Given this list of marker genes TMOD2, MET, PIK3R2, CLASP1, LMOD1 (NCBI Gene Id 25802), TMSB4X, ADD3, CCL21 (NCBI Gene Id 6366), SPTBN4, DNM2, CCL26, WASHC2C, BAIAP2L2, CD2AP (NCBI Gene Id 25916), MAP7D3, MECP2, NCK1, MLST8 (MTOR associated protein, LST8 homolog), TPPP, SKA1, CYRIB, NCK2, FER, CSF3, ARFGEF1, HAX1, PPP2CB, SSH3, PREX1, ASB2, SSNA1, MKKS, CDK5R1, TRIM6 (tripartite motif containing 6), NAV3, CAPZB, HDGFL3, CCDC57, CARMIL2, PLEKHG2, MAPRE1, TPPP3, SPTBN5, AKAP9, CAPG, ESAM, TUBB1, UBE2K, TUBGCP5, STMN1, MICALL2, HAUS3, NIN, TUBGCP4, HAUS7, CDC42EP3, DYRK1A, SLAIN2 (NCBI Gene Id 80106), ARPC2, WASF1, PYCARD, MAPRE3, ANKRD53, TUBGCP6, HCLS1, ADD2, RAC1, NCKAP1L, PRKCD, FLII, WASHC3 (WASH complex subunit 3), FGG (fibrinogen gamma chain), PRKN, FAM107A, PSRC1, TUBG2, GSN, RDX, RICTOR, CDH5, HCK, FES, AVIL, KIRREL1, BAIAP2L1, WASHC5, PRKCE, CHMP4A, CHMP2A, C15orf62, CHMP4B, RPS3, ARPC5L, MZT1, CFL1, TMOD4, CAMSAP2, CKAP5, PFN2, PRUNE1, ABL1, TUBA1A, ARL6, VIL1, TWF2, WASF3, KANK1, VTN, MAP1B, UBE2C, SNX9, CLIP1, CORO1A, DIAPH3, AMBRA1, ALOX15, TMOD3, ARHGAP40, TRIOBP, KRT5, KIF21A, ADD1, HAUS8, CAMSAP1, VASP (NCBI Gene Id 7408), CENPJ, PFN1, PDE4DIP, ARPC4, HAUS2, FGF13, CATIP, HSP90AA1, LMOD2, NUMA1, PFN3, CYFIP1, RNF135, WASL, TRPV4, TRIM32, PINK1, CDC42EP1, DIAPH1, GRB2 (NCBI Gene Id 80715), KANK3, ANG, ARHGAP6, MID1IP1, HSPA1A, MSRB1, MTPN, TMOD1, NME7, CARMIL1, ARHGAP18, WAS, MIR214, KANK4, AIF1, ARPC5, CCL24, PAK3, TUBG1, SSH2, CAPZA2 (capping actin protein of muscle Z-line subunit alpha 2), SPTB, CDC42EP2, CORO7, CCR7, RHOD, RANBP9, ARF6, SNCA, MAP4, CDC42EP5, CAMSAP3, CASQ2, MTOR, EVL, HIP1R, VILL, NDE1, STMN2, COTL1, PIN1, CYRIA, HAUS1, HAUS5, DLG1, CRACD, CDK5RAP2, SPTAN1, ORC4, HSPA1B, SLIT2, CAV3, PPP2CA (NCBI Gene Id 5515), HAUS6, PAK1, NDEL1, DRG1, FHDC1, KANK2, DCTN1, CTTN (NCBI Gene Id 2017), BAG4 (BAG cochaperone 4), EPS8, CLIP3, TWF1, TUBGCP3, ARHGAP28, GPX4, NCKAP1, COBL, CHMP3, LMOD3, ABITRAM, SLAIN1, FBXO5, INPP5J, DMTN, TPPP2, CEP192, CSNK1D, FKBP4, TUBGCP2, ARPC3, TTBK1, CYFIP2 (NCBI Gene Id 81032), EML2, NPHS1, TUBB4A, CLASP2, MAP2, FGA (NCBI Gene Id 2243), CDKN1B (NCBI Gene Id 1027), NEFL, SSH1, FGB, GOLGA2, CAPZA3, SPTBN1, FCHSD1, TBCD, TENM1, ARL2, BAIAP2, FCHSD2, UBE2S, ARHGEF7 (Rho guanine nucleotide exchange factor 7), BIN1, SPTA1, JAK2, PTK2B, HAUS4, CCDC66, INF2, TTC17, CDC42EP4, OCLN, GBA2, TOGARAM1 (NCBI Gene Id 23116), LATS1, ZNF207, ELN, TPX2, SPTBN2, BBS4, PCNT, NEDD1, DAAM2, CASQ1, SLC39A12, MSRB2, GIT1, MAPT, BLOC1S2, DIAPH2, RASA1, SCIN (NCBI Gene Id 85477), MYADM, SVIL, CAPZA1, CCL11, here is a description of the gene set: species: Homo sapiens The process of creating protein polymers, compounds composed of a large number of component monomers; polymeric proteins may be made up of different or identical monomers. Polymerization occurs by the addition of extra monomers to an existing poly- or oligomeric protein. Human Gene Set: GOBP_PROTEIN_POLYMERIZATION